The following is a description of a gene set: species: Homo sapiens Genes down-regulated in at day 0 B cell IRF4-KO versus CD40L and IL-2 IL-4 IL-5 stimulated at day 1 B cell IRF4-KO. Human Gene Set: GSE46606_UNSTIM_VS_CD40L_IL2_IL5_1DAY_STIMULATED_IRF4_KO_BCELL_DN from publication Ochiai K, Maienschein-Cline M, Simonetti G, Chen J, Rosenthal R, Brink R, Chong AS, Klein U, Dinner AR, Singh H, Sciammas R (PMID 23684984) Temporal analysis of B cell activation in vitro using CD40L and IL-2/4/5 cytokines in wild type Irf4+/+ B cells or in mutant Irf4-/- B cells harboring a tet-inducible allele of Irf4. IRF4 expression was restored, or not, in the Irf4-/- background by culturing in the presence of low or high concentrations of doxycycline. The results provide insight in the role of IRF4 expression levels in coordinating different programs of B cell differentiation., and this is the list of marker genes: EMP2 (NCBI Gene Id 2013), ATF7IP, PLXNC1, RNF168, PPM1A, GCNA, HS1BP3, DMXL1, SEMA3F, FSTL3, TKTL1, TGIF1, PDE4D, ITPR1 (inositol 1,4,5-trisphosphate receptor type 1), MED29, HMGB3, LINC00410, WHRN (whirlin), TAF6, RBBP6, ANKRD11 (NCBI Gene Id 92821), FLJ13224, FBN2, KLF13, TPRA1, SRSF12, TNPO2, RAB3IP, AMZ2P1, RAPGEF6, TMEM145, TMOD2, SAP130, SEC22A, TTYH2, LINC03025, CREB5, USP12, FBH1, PABPC3, TSPAN2, GLT8D1, PAIP2, CXCR4, TNFAIP1, KIF13A, CHD2, PITPNC1, TMPRSS4, ST20-AS1, ASMTL, LYSMD2, CYTH1, SLC12A4, PTPN1, RGS2, IL23A, DPP9, THAP3, MTRFR, BRD1, SSH1, GTF2IRD2, NKAPD1, CDYL, ST3GAL1, CDC42EP4, HES1, ABLIM1, GNA12, UNKL, PHC3, CAV1, USP54 (NCBI Gene Id 159195), CD70, ZNF516, XCL1, RAB5B, RARRES1, RHOB, ZNF79, PIK3R3, WNK1, ZMIZ1, NR4A1, PBX2, ZC3H4, PRKCE, TRABD2A, LRIG1, ZNF598, OR3A3, ST6GALNAC6, SYNPO, FXR1, CD86, SPINDOC, ALDH2, CDK2, IL12B, CD40, IFRD1, JOSD1, MLLT11, NCOR2, TAMALIN, ZNF627, BANP, DSTNP2, OTUD7B, CETP, SEMA7A, CLDND1, SH3PXD2A, KRBOX4, CEP68, TBL1X, CACNA2D2, KSR1 (kinase suppressor of ras 1), KIF2C, TTK, POU2F1, NEFH, HTR2B, ARHGEF2, ALPK2, TPST1, GNG4, PKIA, CLCF1, TRIM15 (NCBI Gene Id 91943), RFC2 (replication factor C subunit 2), IL18R1, PDE4B, CGN, MED13, DUSP4, SORL1, SKAP1 (src kinase associated phosphoprotein 1), GSTA4, DSG2, ZNF250, ZNF449, CEP350, KPNA1, PRRC2B, FBXO7, ST8SIA6-AS1, ZSCAN12, TP53BP1, ANKRD50, RBM23, MIR503HG, CREM, PDRG1, PTGR3 (NCBI Gene Id 284273), RETREG1, SNORA71B, PIP5K1B, MMP26, MATN2, IGSF8, NXPH3, LINC00294 (NCBI Gene Id 283267), TSHZ1, FAM107B, LUZP1, HUS1, DYNLRB2, EBF1, ZC2HC1A, RASA1, SLC5A6, KIF21A, S100A3, TLCD3A, UBAC2, CLIP2, DNAJC1, DSTN, AURKA, ENSG00000268472 (novel transcript, antisense to C11orf34), PCDHB17P, SV2B, KCNE5, C1QL1, TFAP2D, MDFIC, WWP1, CDC42SE1, TSPAN13 (NCBI Gene Id 27075), CENATAC (centrosomal AT-AC splicing factor), MVB12B, DCTN2, PDK4 (NCBI Gene Id 5166)